The following is a description of a gene set: Human Gene Set: CEBPDELTA_Q6 species: Homo sapiens Genes having at least one occurrence of the motif MATTKCNTMAYY in the regions spanning 4 kb centered on their transcription starting sites. This matches the CEBPD transcription factor binding site V$CEBPDELTA_Q6 (v7.4 TRANSFAC)., and this is the list of marker genes: SREBF2, IGFALS, EGFR, NNMT, ITGB3BP, GABRB2, PCBP1, SLC44A1, FOXO3, AMMECR1L, RPA3, SLC35C2, CARMIL1, MITF, SLC25A35, PLEKHA6, SFXN2, PTGR3, ODAD4, ZBTB10, HOXA3, DDX52, TNNC2, LHX6, NR4A1, TBC1D10B, TNS2, RORA, ASB18, UBALD2, IKZF2, DCTN2 (dynactin subunit 2), RAB3IP, TFE3, HOXB9, SGIP1, GJB1, APEX2, HOXC4, CDC42, FAM91A1, ABHD11, FEZF2, KCNS3, GLA, LIPG, PCSK2, PLA2G4A, PDE1B, SLC7A11, GLRA2, COPS2, ADK, PTGIR, SPIB, JUN, HEPACAM, NEO1, ARL3, LRATD2, RBM39, KDM6A, ITGBL1, SIAH3, FOS, G0S2, FOXP1, MMGT1, SCYL2, CNOT1, RNF17, DLGAP4, RIN1, NDUFA4L2, C2CD2, CDIN1, SYT11, SRSF1, PTPRN, SPATA8, NEDD4, PAK6, BTLA, PTEN, CER1, ZNF516-DT, GGPS1 (geranylgeranyl diphosphate synthase 1), ARIH1, HOXC13 (NCBI Gene Id 3229), GPR22, ZNF428, VAMP3 (NCBI Gene Id 9341), GPR85, OTP, RNF103, PRDM8, SARNP, NR4A2, GRM7, GAREM1, DTNA, FAM53C, CHST15, SERPINF1, SLC4A10, LMO3, NOTCH1, MID1, ANKRD22, GTF3C2, TAC1, CCNL1 (cyclin L1), FBXW7 (F-box and WD repeat domain containing 7), CNTNAP2, ACE, LINC00114, FCMR, HSH2D, PDAP1, WARS1, IL1RN, S1PR5, STX19, TAL2, CDK6 (NCBI Gene Id 1021), S100A3, RBFOX1, LCOR, GALK2, MARCKS, FOXA2 (NCBI Gene Id 3170), ATF3, MIDEAS, PIK3R1, ZBTB18, MBNL2, ECHDC2, HNRNPH2, SRSF8, UNC13D, ORMDL2, RPH3A, DDX42, ARID1B, C7orf33, ZNF423, DTD2, RARB, BHLHE22, GPD1, GRK2 (G protein-coupled receptor kinase 2), HDGF, RASL10B, HOXA11, HNRNPH1, TLX2, PREPL, ARRDC3 (NCBI Gene Id 57561), TBX6, INTS5, ZNF687, TNKS1BP1, SPRR1B, THRA, NR1H3, IL23A, FOSB, CELF4, EFEMP1, SBSN, LINC00305, WBP1, FOXP2, ITPR3, CAMKMT, ARID4B, STC1, PPM1A, KRT25, SDK1, DPF3, ITGA5, PI15, OSM, FAM24B, CHD2, NEUROD1, FLI1, GABRA3, MAB21L2, DEFB1, BUD31, STC2, NSD1, ZFYVE9, DNASE2B, SMAD1, CCDC47, CLIP1, RC3H2, PPP1R10, TRIB1, DMD, AAR2, CPS1, SEMA3A, NEUROG1, MRPS18B, TSHZ3, PTCH1, TRPM3, NDUFA4, BDNF, SEMA6D, NREP, HOXD12, CFB, ME3, ZEB2, PIPOX, HOXB8, KANK4, MAPK9, USP9X, WNT6, UBE2E2, CACNA2D3, VIPR2, TIMP3, KLK9, ATP13A4, MAP2K3, ANKRD11, MBNL1, CITED2, DOK3, WNT10B, DOCK3, CCND2, H2AZ1, TTC12, CREB5, DAB1, CAVIN2, S100A9, GPC4, FABP4